The following is a description of a gene set: Mouse Gene Set: GOBP_REGULATION_OF_CELLULAR_PH Any process involved in the maintenance of an internal equilibrium of hydrogen ions (protons) within a cell or between a cell and its external environment. species: Mus musculus, and this is the list of marker genes: Slc9a2, Atp6ap1, Rnasek, Bcl2, Atp6v0d1, Atp6v0a4, Slc9a4, Slc4a9 (NCBI Gene Id 240215), Atp6ap1l, Lrrk2, Rab38, Mapk1, Atp1a4, Rab39, Mafg, Atp6v0c, Slc9a6, Slc26a3, Avpr1a, Gpr39, Slc4a7, Creg1, Tmem165, Atp6v0a1, Atp6v1b2, Grn, Atp5f1b, Tasl, Slc9a3, Gpr89, Slc4a8, Tpcn2, Ppt1, Atp6v0a2, Snapin, Tmem175, Tmem199, Vps33a (NCBI Gene Id 77573), Rab20, Ube3a, Ttpa, Tm9sf4, Cln3, Spns1, Car7, Ccdc115 (NCBI Gene Id 69668), Slc45a2, Atp6v1b1, Aqp11, Slc12a5, Dmxl1, Slc4a1, Cftr, Lacc1, Lamp1, Slc9a9, Mapk3, Rab7, Slc9a5, Slc26a6, Oca2, Slc11a1, Car2, Slc9a8, Slc4a2, Clic4, Atp6ap2, Slc4a5, Cln5, Slc9c1, Dmxl2, Lamp2, Slc9b1, Atp6v0d2, Slc4a4 (NCBI Gene Id 54403), Slc4a3, Fasl, Avp (arginine vasopressin), Tmem106b, Cln6, Slc9a1, Slamf8, Tmem9, Trp53 (NCBI Gene Id 22059), Tcirg1, Slc9a7, Clcnkb, Slc4a10 (solute carrier family 4, sodium bicarbonate cotransporter-like, member 10), Hvcn1, Chp1